Given this list of marker genes CLEC5A, DIO1, ADGRL3, LY6G6E (NCBI Gene Id 79136), GTF3C3, IKZF4, KERA, B4GALT2, CHRNA6, BAG2, RBFOX1, SPATA31C2, GRK1, HOMER1, CRYGB, SCLY, EGF, ZNF556, SFTPB, PRKAB2, FGF4, WWC2, CCL4, CXCL1, ACAD10, ZFY, RLF, LRRC37A2, RAD54L, GPD1L, MAP2K6, PLCB3, TRIAP1, SEPTIN8, COL2A1, ADAP2, SOD2, TNFAIP3, TUBG1, KCNK5, HABP2, PRAMEF12, BAMBI, PTPRK, BBS10, DGKE, CDH19, RPL13, KRT76, C2orf72, CLDN1 (NCBI Gene Id 9076), ARHGEF4, PRRG1 (proline rich and Gla domain 1), SLC15A2 (solute carrier family 15 member 2, NCBI Gene Id 6565), APOF (NCBI Gene Id 319), ADISSP, ACTL8, CEBPZ, TSPYL5, SPN, MRM1, HCAR3, SLC25A38, ABCB1, GPR176, CXCL2, TTLL7, GOLPH3L, ZNF221, SOX18, ARHGAP33, NDUFS4, SYNJ2BP, ARSJ, EPB41L5, PRND, RRS1, RELN, UAP1L1 (NCBI Gene Id 91373), DHFRP3, PDE4D, C1QTNF1, GSPT2, ATF7IP2, IDH3A, NR4A2, MTCL2, FKRP, MUC3A, CLDN8, VRTN, PYHIN1, EFR3B, LPL, SPTBN4, SLC28A1, CSE1L, ESF1, P4HB, LRP3, DNASE1L2, OR7E156P, ZNF500, TEDC2, SNTA1, CCN6, TLE6, LDHA, SLC11A2, HOXC6, CDT1, PTHLH, TMEM255A (NCBI Gene Id 55026), TNFSF9, RGS16, MTMR7, MTCL1, SPACA9, ZNF432, AEN, TNP2, GREM1, GEMIN2, MNS1, USP53, PRKG2, UNC5B, RUNDC3A, LHCGR, TMEM97, TK1, NUDT7, SPAG5, ZNF528, DLGAP5, POU5F1P4, XPNPEP3, MC5R, ITGA2, EMP1, WDR18, ANGPTL2, TPI1, EIPR1, OPTN, CSNK1G1, LTK (leukocyte receptor tyrosine kinase), ARPIN, ST18, RFK, THRB, EGR3, ANGPTL7, RPP30, INHBA, KRT13, HILPDA, IL1B, G0S2, OSM, ALDH8A1, ATG10, PRAMEF10, IREB2, ACTL6B, ADAMDEC1, SH2D4A, CACFD1, MTTP, BCL2A1, POM121L2, TOX, RINT1, NFKBIA, SAG, FGGY, CD83, ATF3, BMP2, COPS8, FAM114A2, SCD5, PNO1, MAFB, CLEC1B, C3, PIWIL1, CRYBB2, CASQ2, FILIP1L, ONECUT1, GTF2H4, EPHX2, MUC5B, CA2, here is a description of the gene set: Genes up-regulated in CD8 T cells: IL10+ versus IL10-. IL-10 is an anti-inflammatory cytokine that has been shown to be produced by antigen-specific CD8 T cells at the peak of viral encephalitis. We found that IL-10+CD8 T cells are more activated and cytolytic than IL-10-CD8 T cells. We used microarrays to detect gene expression changes in directly ex vivo sorted CNS IL-10+ and IL-10- CD8 T cells from a neurotropic J2.2-V-1-infected mouse. Human Gene Set: GSE25846_IL10_POS_VS_NEG_CD8_TCELL_DAY7_POST_CORONAVIRUS_BRAIN_UP from publication Trandem K, Zhao J, Fleming E, Perlman S (PMID 21317392) studied in species Homo sapiens